Given this list of marker genes Nub1, Herpud1, Sqstm1, Fbxo7, Arih1, Atf4, Gpx1, here is a description of the gene set: Cytoplasmic, spherical inclusion commonly found in damaged neurons, and composed of abnormally phosphorylated, neurofilament proteins aggregated with ubiquitin and alpha-synuclein. Mouse Gene Set: GOCC_LEWY_BODY species: Mus musculus